The following is a description of a gene set: species: Mus musculus Mouse Gene Set: REACTOME_HDL_REMODELING HDL remodeling, and this is the list of marker genes: Alb, Apoc2, Lipg, Apoe, Apoa1, Apoc2l, Lcat, Pltp, Abcg1